Given this list of marker genes Adora2a, P2ry13, P2ry10, P2ry14, P2ry6, Adora3, Lpar4, Adora1, Lpar6, Gpr17, P2ry4, P2ry2, Adora2b, P2ry1, P2ry12, here is a description of the gene set: studied in species Mus musculus Mouse Gene Set: REACTOME_NUCLEOTIDE_LIKE_PURINERGIC_RECEPTORS Nucleotide-like (purinergic) receptors